The following is a description of a gene set: Genes down-regulated in MEF cells (embryonic fibroblast) upon knockout of NFIC. species: Mus musculus from publication Plasari G, Calabrese A, Dusserre Y, Gronostajski RM, McNair A, Michalik L, Mermod N (PMID 19752192) Transforming growth factor beta (TGF-beta) and platelet-derived growth factor A (PDGFAlpha) play a central role in tissue morphogenesis and repair, but their interplay remain poorly understood. The nuclear factor I C (NFI-C) transcription factor has been implicated in TGF-beta signaling, extracellular matrix deposition, and skin appendage pathologies, but a potential role in skin morphogenesis or healing had not been assessed. To evaluate this possibility, we performed a global gene expression analysis in NFI-C(-/-) and wild-type embryonic primary murine fibroblasts. This indicated that NFI-C acts mostly to repress gene expression in response to TGF-beta1. Misregulated genes were prominently overrepresented by regulators of connective tissue inflammation and repair. In vivo skin healing revealed a faster inflammatory stage and wound closure in NFI-C(-/-) mice. Expression of PDGFA and PDGF-receptor alpha were increased in wounds of NFI-C(-/-) mice, explaining the early recruitment of macrophages and fibroblasts. Differentiation of fibroblasts to contractile myofibroblasts was also elevated, providing a rationale for faster wound closure. Taken together with the role of TGF-beta in myofibroblast differentiation, our results imply a central role of NFI-C in the interplay of the two signaling pathways and in regulation of the progression of tissue regeneration. Human Gene Set: PLASARI_NFIC_TARGETS_BASAL_DN, and this is the list of marker genes: EPHB2, CCN3, INSIG1, RBP1, EPHA3, MEOX1, FLI1, PDGFRA, LSS, RPL39L, PIK3AP1, IFI16, AHR, MFAP4, STARD4, EBF3, VWA5A, CCL2, IGFBP6, SLIT2, ENPEP